Given this list of marker genes Als2, Rnf26rt, Dnm1, Washc1, Stx12, Plekhj1, Pi4k2a, Tom1, Rab22a, Lamtor1, Sqstm1, Aqp11, Snx33 (NCBI Gene Id 235406), Vps4a, Pheta2, Vps4b, Fhip1b, Rab5c, Chmp6, Chmp7, Rab27a, Anxa8, Aktip, Rnf26, Chmp2a (charged multivesicular body protein 2A), Tmem127, Vps18, Plekhf1, Tmcc1, Snx10, Rilp, Arfgef2, Pik3c3, Tmem9 (transmembrane protein 9), Usp8, Plekhf2, Cc2d1a, Synj1, Vps33b, Vamp4, Chmp1b2, Chmp3, Snf8, Chmp5, Hook2, Als2cl, Micall2, Coro1c, Hook1, Chmp1a (NCBI Gene Id 72909), Rnasek, Usp50, Chmp1b, Chmp2b, Vti1a, Rab11a, Ubr4, Rab5b, Vps11, Chmp4c, Fasl, Stx7, Hook3, Prkn, Pheta1, Exoc8, Pi4k2b, Laptm4b, Washc4, Dnajc13, Stx6, Washc5, Plekha3, Chmp4b, Snx3, here is a description of the gene set: A process that is carried out at the cellular level which results in the assembly, arrangement of constituent parts, or disassembly of endosomes. studied in species Mus musculus Mouse Gene Set: GOBP_ENDOSOME_ORGANIZATION